The following is a description of a gene set: from publication Riz I, Akimov SS, Eaker SS, Baxter KK, Lee HJ, Mariño-Ramírez L, Landsman D, Hawley TS, Hawley RG (PMID 17213805) Mouse Gene Set: RIZ_ERYTHROID_DIFFERENTIATION_HEMGN Aberrant expression of the human homeobox-containing proto-oncogene TLX1/HOX11 inhibits hematopoietic differentiation programs in a number of murine model systems. Here, we report the establishment of a murine erythroid progenitor cell line, iEBHX1S-4, developmentally arrested by regulatable TLX1 expression. Extinction of TLX1 expression released the iEBHX1S-4 differentiation block, allowing erythropoietin-dependent acquisition of erythroid markers and hemoglobin synthesis. Coordinated activation of erythroid transcriptional networks integrated by the acetyltransferase co-activator CREB-binding protein (CBP) was suggested by bioinformatic analysis of the upstream regulatory regions of several conditionally induced iEBHX1S-4 gene sets. In accord with this notion, CBP-associated acetylation of GATA-1, an essential regulator of erythroid differentiation, increased concomitantly with TLX1 downregulation. Coimmunoprecipitation experiments and glutathione-S-transferase pull-down assays revealed that TLX1 directly binds to CBP, and confocal laser microscopy demonstrated that the two proteins partially colocalize at intranuclear sites in iEBHX1S-4 cells. Notably, the distribution of CBP in conditionally blocked iEBHX1S-4 cells partially overlapped with chromatin marked by a repressive histone methylation pattern, and downregulation of TLX1 coincided with exit of CBP from these heterochromatic regions. Thus, we propose that TLX1-mediated differentiation arrest may be achieved in part through a mechanism that involves redirection of CBP and/or its sequestration in repressive chromatin domains. Selected gradually up-regulated genes whose expression profile follows that of HEMGN in the TLX1 Tet On iEBHX15-4 cells (pro-erythroblasts). studied in species Mus musculus, and this is the list of marker genes: Klf5, Nr0b2, Sox1, Sox4, Pou3f3, Ncoa1, Foxa1, Hoxa2, Sox18, Cux1, Eya2, Zfp46, Nfe2l3, Pbx3, Nr4a2, Ell2, Tmpo, Nr2f1, Nkx2-5 (NK2 homeobox 5), Fosb, Runx1t1, Mpl, Tbx2, Tal2, Pou2f3, E2f8